The following is a description of a gene set: studied in species Homo sapiens from publication Chen Y, Wang X (PMID 31504780) Genes predicted to be targets of miRBase v22 microRNA hsa-miR-4652-5p in miRDB v6.0 with MirTarget v4 prediction scores > 80 (high confidence targets). Human Gene Set: MIR4652_5P, and this is the list of marker genes: VTI1A, KIAA0040, COG5, KCTD15, PPP1R9B, SHISAL1, CD19, CABYR, SLC25A32, SLC35F1, FIGNL2, DNAJC15, STIMATE, ZNF285, IP6K2, CLEC17A, PSMD5, WDR72, CDH4, TRAM1, ISCU, ZNF714, GJB1, TTLL5, SNX20, SIDT1, EPB41L1, PIP5K1C, ZFTA, ZNF664, MXRA8, BNC2, SLF2, BBC3, RND1, USP3, ATF6B